Given this list of marker genes SHANK3, MIR320B1, CALM3, INS (NCBI Gene Id 3630), CALM1, MIR320D1, ADCY8, GRIA1, GRIN2A, NFATC4, CALM2, MIR421, AGER, MIR342, MIR433, RELN, MECP2, CREB1, LGMN, STX4, MIR337, S100B, CAMK2G, MIR320C2, EPHA4, MIR320E, NR2E1, DRD2, NSG1, PRKCZ, ITPR3, PRKCG, SLC24A1, SLC24A2, MIR320B2, MIR320A, MPP2, RASGRF2, MAPK1 (NCBI Gene Id 5594), MIR30B, MIR320D2, CYP46A1, VAMP2, CAMK2D, YTHDF1, ADORA1 (NCBI Gene Id 134), SQSTM1, NRGN, ABL1, GRIN2D, LRRTM2, SHISA7, LILRB2, GFAP, ADCY1, DRD1, SLC18A3, MME, ARC, CHRNA7, SLITRK4, NF1, NOG, MIR541, TYROBP, STAU1, MIR324 (NCBI Gene Id 442898), LARGE1, FXR1, BRAF, CRHR2, CRH, PRNP, PAIP2, SNCA, MIR95, SERPINE2, PLK2, SLC8A3, AKAP5, IGSF11, PRRT1 (proline rich transmembrane protein 1), GRIA3, PDE9A, PRKAR1B, NPTN, GRIN2B, RGS14, TNR, GRIN2C, ZDHHC2 (zinc finger DHHC-type palmitoyltransferase 2), APOE, SLC8A2, APP, EPHB2, GSK3B, MIR320C1, TSHZ3, NCSTN, SNAP25, EIF2AK4, SLC1A1, CAMK2A (calcium/calmodulin dependent protein kinase II alpha), LRRTM1, PTN, NTRK2, FAM107A, ADORA2A, MIR545, HMGCR, SYT12, SHANK2, CAMK2B, PTK2B, C22orf39, STX3, here is a description of the gene set: studied in species Homo sapiens A process that modulates synaptic plasticity such that synapses are changed resulting in the increase in the rate, or frequency of synaptic transmission at the synapse. Human Gene Set: GOBP_LONG_TERM_SYNAPTIC_POTENTIATION